Given this list of marker genes MTRR, MMAB, AMN, MMAA, CLYBL, MTR, ABCD4, CUBN, MMACHC, MMADHC (metabolism of cobalamin associated D), here is a description of the gene set: The chemical reactions and pathways involving cobalamin (vitamin B12), a water-soluble vitamin characterized by possession of a corrin nucleus containing a cobalt atom. species: Homo sapiens Human Gene Set: GOBP_COBALAMIN_METABOLIC_PROCESS